Given this list of marker genes WARS1 (tryptophanyl-tRNA synthetase 1), FBLN5, LIFR, GNB4, MFN2, HSPB3, KLHL9, SMN1, SMN2, PSMC1, MYH14, PMP2, ERLIN1, here is a description of the gene set: Absent patellar reflexes Absence of the knee jerk reflex, which can normally be elicited by tapping the patellar tendon with a reflex hammer just below the patella. species: Homo sapiens Human Gene Set: HP_ABSENT_PATELLAR_REFLEXES